Given this list of marker genes CNTN5, PCDHA9, CD69, BLVRB, LPAR6 (NCBI Gene Id 10161), SLC2A3, MATN1, GAPDH (NCBI Gene Id 2597), STOM, CA4, MAFF, NECTIN2, here is a description of the gene set: studied in species Homo sapiens from publication Holleman A, Cheok MH, den Boer ML, Yang W, Veerman AJ, Kazemier KM, Pei D, Cheng C, Pui CH, Relling MV, Janka-Schaub GE, Pieters R, Evans WE (PMID 15295046) Human Gene Set: HOLLEMAN_PREDNISOLONE_RESISTANCE_B_ALL_DN Childhood acute lymphoblastic leukemia (ALL) is curable with chemotherapy in approximately 80 percent of patients. However, the cause of treatment failure in the remaining 20 percent of patients is largely unknown. Genes distinguishing prednisolone resistant and sensitive B-lineage ALL; here - genes down-regulated in the drug resistant samples.